The following is a description of a gene set: studied in species Homo sapiens Human Gene Set: HP_MECONIUM_ILEUS Meconium ileus Obstruction of the intestine due to abnormally thick meconium., and this is the list of marker genes: SLC9A3, SLC6A14, MIF, FCGR2A, HMOX1, CEACAM6, KCNN4, EDNRA, SLC26A9, CEACAM3, TGFB1, SERPINA1, SLC18A3, DCTN4, GCLC, SLC11A1, STX1A, CFTR, GUCY2C, CLCA4, HFE, GSTM3